The following is a description of a gene set: Enables the energy-independent facilitated diffusion of ammonium through a transmembrane aqueous pore or channel. species: Mus musculus Mouse Gene Set: GOMF_AMMONIUM_CHANNEL_ACTIVITY, and this is the list of marker genes: Rhd, Aqp1, Aqp6, Slc12a6, Slc12a5, Rhbg, Rhcg (Rhesus blood group-associated C glycoprotein), Aqp8, Slc12a2, Rhag